Given this list of marker genes NABP1, RORC, IL12A, FASLG, FIP1L1 (NCBI Gene Id 81608), CD40LG, KYNU, IL12A-AS1, NLRP12, CARMIL2, TBL1XR1 (NCBI Gene Id 81612), MMACHC, MALT1, CASP10, PML, IRF2BP2, HLA-B, SRP19, TLR4, ITK, PRKDC, SLC37A4, TCIRG1, RARA, STAT3, TLR8, BCOR, GCGR, ORAI1, STK4, IL10 (NCBI Gene Id 3586), FAS, SEC61A1, TICAM1, CEBPE, LMBRD1, C4A, NOD2, IL23R, MEFV, CCR1, CLPB (ClpB family mitochondrial disaggregase), ZBTB16, NUMA1, HLA-DQB1, IL6, RNF125, DCLRE1C, NCF4, UBAC2, IL1RN, PRKAR1A, ELANE, ERAP1, STAT5B, IFNGR1, IRF9, RHOH, STAT4, NPM1, RIN2, GFI1, HYOU1, MVK, KLRC4, HLA-DQA1, IL17RC, WDR1, ZAP70 (zeta chain of T cell receptor associated protein kinase 70), NLRP3, here is a description of the gene set: species: Homo sapiens Stomatitis Stomatitis is an inflammation of the mucous membranes of any of the structures in the mouth. Human Gene Set: HP_STOMATITIS